Given this list of marker genes HRAS, COL9A2, PSPN, FGFR1, ARTN, NRAS, AGRN, COL5A1, CACNB3, GFRA2, SPTB, FYN, RPS6KA5, GRB2, SPTA1 (NCBI Gene Id 6708), CACNA1I, ST8SIA4 (ST8 alpha-N-acetyl-neuraminide alpha-2,8-sialyltransferase 4), COL4A4, MAPK3, COL4A1, NCAN, COL2A1, PTPRA, COL6A2, CACNA1H, COL3A1, PTK2, SOS1, COL5A3, CACNA1D, COL4A5, NRTN, CACNB2, CACNA1C, GFRA4, NCAM1, SPTBN4 (spectrin beta, non-erythrocytic 4), COL6A3, GDNF, CACNA1G, CREB1, GFRA1, ST8SIA2, COL6A6, PRNP, MAPK1, COL5A2, COL9A1, CACNB4, COL6A1, COL6A5, CNTN2, COL4A3, CACNB1, KRAS, SRC, SPTBN1, SPTBN5, SPTAN1, COL9A3, COL4A2, CACNA1S, SPTBN2, here is a description of the gene set: Reactome Pathway: NCAM signaling for neurite out-growth The neural cell adhesion molecule, NCAM, is a member of the immunoglobulin (Ig) superfamily and is involved in a variety of cellular processes of importance for the formation and maintenance of the nervous system. The role of NCAM in neural differentiation and synaptic plasticity is presumed to depend on the modulation of intracellular signal transduction cascades. NCAM based signaling complexes can initiate downstream intracellular signals by at least two mechanisms: (1) activation of FGFR and (2) formation of intracellular signaling complexes by direct interaction with cytoplasmic interaction partners such as Fyn and FAK. Tyrosine kinases Fyn and FAK interact with NCAM and undergo phosphorylation and this transiently activates the MAPK, ERK 1 and 2, cAMP response element binding protein (CREB) and transcription factors ELK and NFkB. CREB activates transcription of genes which are important for axonal growth, survival, and synaptic plasticity in neurons.<br><br>NCAM1 mediated intracellular signal transduction is represented in the figure below. The Ig domains in NCAM1 are represented in orange ovals and Fn domains in green squares. The tyrosine residues susceptible to phosphorylation are represented in red circles and their positions are numbered. Phosphorylation is represented by red arrows and dephosphorylation by yellow. Ig, Immunoglobulin domain; Fn, Fibronectin domain; Fyn, Proto-oncogene tyrosine-protein kinase Fyn; FAK, focal adhesion kinase; RPTPalpha, Receptor-type tyrosine-protein phosphatase; Grb2, Growth factor receptor-bound protein 2; SOS, Son of sevenless homolog; Raf, RAF proto-oncogene serine/threonine-protein kinase; MEK, MAPK and ERK kinase; ERK, Extracellular signal-regulated kinase; MSK1, Mitogen and stress activated protein kinase 1; CREB, Cyclic AMP-responsive element-binding protein; CRE, cAMP response elements. part of: Axon guidance studied in species Homo sapiens